The following is a description of a gene set: Mouse Gene Set: MIR_122_3P from publication Chen Y, Wang X (PMID 31504780) studied in species Mus musculus Genes predicted to be targets of miRBase v22 microRNA mmu_miR_122_3p in miRDB v6.0 with MirTarget v4 prediction scores > 80 (high confidence targets)., and this is the list of marker genes: Npepps, Ints12, Tars1, A930009A15Rik, Cbfb